The following is a description of a gene set: Genes predicted to be targets of miRBase v22 microRNA mmu_miR_6973b_3p in miRDB v6.0 with MirTarget v4 prediction scores > 80 (high confidence targets). from publication Chen Y, Wang X (PMID 31504780) studied in species Mus musculus Mouse Gene Set: MIR_6973B_3P, and this is the list of marker genes: Zfp418, Mat2a, Rufy3, Irag1, Bag5, Efemp1, Dhdh, Pde7a, Magea13, Mecp2, Mtmr4, Exoc6b, Tnik, Mup1, Exd1, Usp33, Trappc3, Klf14, Lrch3, Pbxip1, Cnst, Mdfic, Ccdc43, Cdk14, Ms4a1, Marchf6, Gpbp1l1, Gpr161, Fam167b (NCBI Gene Id 230766), Oprm1, Ppp1cc, Ntrk2, Mis12, Pdgfc, Slc17a6, Tmed8, Hoxa9 (NCBI Gene Id 15405), Tbc1d22a, Ythdf1, Hdac9, Cyp2j13, Zfp11, Ddt, Trpm3, Ephb3, Pilra, Mtus1, Plp1, Nfatc2, Rprd2, Acin1, Mup2, Fbxw8, Ak3, Pigh, Gpc6 (NCBI Gene Id 77735), Fyn, Ammecr1, Ak5, Spint2, Lpin2, Cep76, Ar, H2bw2, Hes1, Raph1, Sh3glb1